Given this list of marker genes RABEPK, CBR4, BAG2, FDXR, NCKIPSD, LRRC37A2, KIF1C, CSF2RB, REPIN1, NAT10, NEIL3, MAP3K4, TMEM184B, EI24, GLCE, YY1AP1, CAD, ADCY7, PPP5C, NME6, PRIM1, GGNBP2, ADCY3, RAD17, FIS1, TARS2, LRCH4, DIAPH1, MRPS11 (NCBI Gene Id 64963), SLC39A14, HPS4, GGA1, SMG8, GRIA2, SMIM8, PUDP, RPRD2, NUP50, ANAPC13, RMI1, CEP72 (NCBI Gene Id 55722), ORC5, POLR2B, TUBG1 (NCBI Gene Id 7283), PLAU, PSMG2, MIEF1, NCOA6, ZNF175 (NCBI Gene Id 7728), TMEM223, MGA, SENP3, PIK3C2B (NCBI Gene Id 5287), CEP68 (NCBI Gene Id 23177), KMT2D, MKRN2, CIT, PPP1CC, BANP, COLGALT1, TXNDC15, ESS2, NDE1, THUMPD1, PPAT, KDELR3, CCNA2, CHST10, PAQR4, FAM193B, BLTP2, BRCC3, CD244, PMS2P5, LRRC1, REPS1, BLCAP (NCBI Gene Id 10904), RNF4, FAM89B, PLIN3, PACSIN2, MRTFB, AHSA1, TRIM26, MPI, SNX17, C2CD2L, ZFTA, CEP350, ASH2L, CBX7, SETD2, NDST1, GDE1, RNF31, ARHGEF3, TSC1, SNAPC1, DALRD3, TUBA4A, TOB1, FAM86B1, MEA1, ELAVL1, UBB, PPFIA3, GGCT, FN3KRP, FNBP1, GPHN, CBX5, C17orf75, VDAC3, ACTR8, RIOX1, RIN3, RNF146, MRPL35, ALDH5A1, SYNE1, TMEM187, SSR1, PCYOX1L, TAL1, NUP107, CCND3, KIFAP3, ZNF573 (NCBI Gene Id 126231), ZNF22, ADD1, SEC24C, GORASP1, BRD7, ZNF184, ZNF443, BEX4, EXOC1, ACTR5, PRR13, CTBP1, NQO2, PRMT2, SLC12A7, RPS6KB1, CREBZF, TOE1, LSM1, UBE2L3, MAML1, CBX3, PAGR1, ZNF440, ENTPD3, STAM, MPHOSPH10, AATF, NSFL1C, ERMAP, MSH6, FZD1, BICDL1, PDS5B, SKIC2, PCYT2, TMEM177, ACAD8, POP4, ZBTB18, TJP2, KRI1, PARP2, RAB5IF, SS18L1, UBA3, ATP5PD, BMPR1A, CCDC92, ARHGEF2, FTO (FTO alpha-ketoglutarate dependent dioxygenase), LSM14A, PTPA, MDC1, FAM117A, PIK3R3, TNRC6B, SNAPC4, AGPAT2, THAP11 (THAP domain containing 11), GRK5, RRP1B, ZNF177, SPOUT1, LIMD1, TROAP, SLC38A10, HTRA2, MPIG6B, KPNA6, CDC23, here is a description of the gene set: Genes down-regulated in bone marrow-derived dendritic cellstreated by poly(IC): 0h versus 3h. from publication Olex AL, Hiltbold EM, Leng X, Fetrow JS (PMID 20682054) species: Homo sapiens BACKGROUND: Dendritic cells (DC) play a central role in primary immune responses and become potent stimulators of the adaptive immune response after undergoing the critical process of maturation. Understanding the dynamics of DC maturation would provide key insights into this important process. Time course microarray experiments can provide unique insights into DC maturation dynamics. Replicate experiments are necessary to address the issues of experimental and biological variability. Statistical methods and averaging are often used to identify significant signals. Here a novel strategy for filtering of replicate time course microarray data, which identifies consistent signals between the replicates, is presented and applied to a DC time course microarray experiment. RESULTS: The temporal dynamics of DC maturation were studied by stimulating DC with poly(I:C) and following gene expression at 5 time points from 1 to 24 hours. The novel filtering strategy uses standard statistical and fold change techniques, along with the consistency of replicate temporal profiles, to identify those differentially expressed genes that were consistent in two biological replicate experiments. To address the issue of cluster reproducibility a consensus clustering method, which identifies clusters of genes whose expression varies consistently between replicates, was also developed and applied. Analysis of the resulting clusters revealed many known and novel characteristics of DC maturation, such as the up-regulation of specific immune response pathways. Intriguingly, more genes were down-regulated than up-regulated. Results identify a more comprehensive program of down-regulation, including many genes involved in protein synthesis, metabolism, and housekeeping needed for maintenance of cellular integrity and metabolism. CONCLUSIONS: The new filtering strategy emphasizes the importance of consistent and reproducible results when analyzing microarray data and utilizes consistency between replicate experiments as a criterion in both feature selection and clustering, without averaging or otherwise combining replicate data. Observation of a significant down-regulation program during DC maturation indicates that DC are preparing for cell death and provides a path to better understand the process. This new filtering strategy can be adapted for use in analyzing other large-scale time course data sets with replicates. Human Gene Set: GSE21033_CTRL_VS_POLYIC_STIM_DC_3H_DN